Given this list of marker genes PELO, CDH11, ANGPT1, DPEP1, RUNX3, PMP22, ERBB2, COL4A1, KLF10, VEGFA, SDC1, DLK1, BMP7, ITGAV, DDR2, MYC, DAB2, IGF1R, AGT, AGRN, COL4A2, FRZB, SPP1, GATA3, COL5A1, INHBA, IGFBP5, TGFBR3, THBS1, APOE (NCBI Gene Id 99), CDH6, TGFA, RET, FZD1, TIMP3, GPC4, TGFBR2, RARG, CDH1, CX3CL1, IGFBP6, ALCAM, ITGA2, GNG11, SEMA3C, SELENOP, LHX1, EGF, here is a description of the gene set: species: Homo sapiens Genes down-regulated in Wilm's tumor vs fetal kidney. from publication Li W, Kessler P, Williams BR (PMID 15531917) Human Gene Set: LI_WILMS_TUMOR_VS_FETAL_KIDNEY_2_DN Anaplasia (unfavorable histology) is associated with therapy resistance and poor prognosis of Wilms tumor, but the molecular basis for this phenotype is unclear. Here, we used a cDNA array with 9240 clones relevant to cancer biology and/or kidney development to examine the expression profiles of 54 Wilms tumors, five normal kidneys and fetal kidney. By linking genes differentially expressed between fetal kidney and Wilms tumors to kidney morphogenesis, we found that genes expressed at a higher level in Wilms tumors tend to be expressed more in uninduced metanephrogenic mesenchyme or blastema than in their differentiated structures. Conversely, genes expressed at a lower level in Wilms tumors tend to be expressed less in uninduced metanephrogenic mesenchyme or blastema. We also identified 97 clones representing 76 Unigenes or unclustered ESTs that clearly separate anaplastic Wilms tumors from tumors with favorable histology. Genes in this set provide insight into the nature of the abnormal nuclear morphology of anaplastic tumors and may facilitate identification of molecular targets to improve their responsiveness to treatment.